The following is a description of a gene set: Mouse Gene Set: REACTOME_THE_FATTY_ACID_CYCLING_MODEL The fatty acid cycling model studied in species Mus musculus, and this is the list of marker genes: Slc25a14 (solute carrier family 25 (mitochondrial carrier, brain), member 14), Ucp2, Slc25a27, Ucp3, Ucp1